The following is a description of a gene set: Reactome Pathway: Recognition and association of DNA glycosylase with site containing an affected pyrimidine electronically inferred by orthology from the curated human pathway This event has been computationally inferred from an event that has been demonstrated in another species.<p>The inference is based on the homology mapping from PANTHER. Briefly, reactions for which all involved PhysicalEntities (in input, output and catalyst) have a mapped orthologue/paralogue (for complexes at least 75% of components must have a mapping) are inferred to the other species. studied in species Mus musculus part of: Depyrimidination, and this is the list of marker genes: Neil1